Given this list of marker genes CDKN1A, H1-0 (H1.0 linker histone), ASF1A, EP400, CABIN1, HMGA1, H1-3, TP53, HMGA2, UBN1, H1-2, RB1, H1-5, H1-1, LMNB1, H1-4, HIRA, here is a description of the gene set: The process of DNA damage/telomere stress induced senescence culminates in the formation of senescence associated heterochromatin foci (SAHF). These foci represent facultative heterochromatin that is formed in senescent cells. They contribute to the repression of proliferation promoting genes and play an important role in the permanent cell cycle exit that characterizes senescence (Narita et al. 2003 and 2006). SAHF appear as compacted, punctate DAPI stained foci of DNA. Each chromosome is condensed into a single SAH focus, with telomeric and centromeric chromatin located predominantly at its periphery.<p>An evolutionarily conserved protein complex of HIRA, ASF1A, UBN1 and CABIN1 plays a crucial role in the SAHF formation. As cells approach senescence, HIRA, ASF1A, UBN1 and CABIN1 accumulate at the PML bodies. PML bodies are punctate nuclear structures that contain PML protein and numerous other proteins and are proposed to be the sites of assembly of macromolecular regulatory complexes and protein modification. Recruitment of HIRA to PML bodies coincides with altered chromatin structure and deposition of macroH2A histone H2A variant onto chromatin. As cells become senescent, HIRA, ASF1A, UBN1 and CABIN1 relocate from PML bodies to SAHF. HIRA accumulation at PML bodies is RB1 and TP53 independent, but may require phosphorylation of HIRA serine S697 by GSK3B (Ye, Zerlanko, Kennedy et al. 2007). SAHF formation itself, however, requires functional RB1 and TP53 pathways (Ye, Zerlanko, Zhang et al. 2007).<p>SAHF contain H3K9Me mark, characteristic of trancriptionally silent chromatin, and HP1, marcoH2A histone H2A variant and HMGA proteins are also components of SAHF, besides the HIRA:ASF1A:UBN1:CABIN1 complex. A yet unidentified H3K9Me histone methyltransferase may be recruited to SAHF by UBN1. One of the functions of the HIRA:ASF1A:UBN1:CABIN1 complex is to deposit histone H3.3. variant to chromatin, which influences gene expression.<p>Further studies are needed to fully elucidate the mechanism of SAHF formation and mechanism by which SAHF promote cell senescence. part of: DNA Damage/Telomere Stress Induced Senescence studied in species Homo sapiens Reactome Pathway: Formation of Senescence-Associated Heterochromatin Foci (SAHF)